The following is a description of a gene set: A complex that mediates intra-Golgi traffic, Golgi exit, endosome-to-Golgi traffic, and the trafficking of autophagy proteins from Golgi to the phagophore assembly site. Binds to a component of the COPI coat. In yeast it includes the following subunits: Bet3 (as homodimer), Bet5, Tca17, Trs20, Trs23, Trs31, Trs33, Trs65, Trs120, Trs130. The whole complex is thought to dimerize with itself. species: Mus musculus Mouse Gene Set: GOCC_TRAPPII_PROTEIN_COMPLEX, and this is the list of marker genes: Trappc4, Trappc6b, Trappc3, Trappc10, Trappc5, Trappc9, Trappc13, Trappc2l, Trappc14 (NCBI Gene Id 231807), Trappc2, Trappc1